Given this list of marker genes HPRT1, ADK, NT5E, DTYMK, LCMT2, ADA, MTAP, UCKL1, QNG1, TK1, TYW5, TYW1, TYW3, MAPDA, DNPH1, PRTFDC1, APRT, TRMT12, TK2, ADA2, DHFR2 (NCBI Gene Id 200895), PNP, DCTD, TYW1B, PGM2, here is a description of the gene set: species: Homo sapiens The chemical reactions and pathways resulting in the formation of glycosyl compound. Human Gene Set: GOBP_GLYCOSYL_COMPOUND_BIOSYNTHETIC_PROCESS